The following is a description of a gene set: Generation of a long process from a neuron whose cell body resides in the central nervous system. The process carries efferent (outgoing) action potentials from the cell body towards target cells. Human Gene Set: GOBP_CENTRAL_NERVOUS_SYSTEM_NEURON_AXONOGENESIS species: Homo sapiens, and this is the list of marker genes: NDEL1, ARHGAP35, B4GALT6, CHRNB2, DRAXIN, SPTBN4, WDR47, CDH11, ZEB2, TCTN1, ADARB1, SPG11, PHOX2B, EPHB3, B4GALT5, PLXNA4, NIN, SCN1B (NCBI Gene Id 6324), PAFAH1B1, KIFBP, EPHA4, DCC, SZT2, MYCBP2, EPHB1, ARHGEF28, C12orf57, FBXO45, TSKU, EPHB2, PRDM8, PRKCA, NR4A2, GLI2, NFIB, PTEN, NR2E1, SLIT2